The following is a description of a gene set: studied in species Mus musculus Mouse Gene Set: MIR_5619_5P Genes predicted to be targets of miRBase v22 microRNA mmu_miR_5619_5p in miRDB v6.0 with MirTarget v4 prediction scores > 80 (high confidence targets). from publication Chen Y, Wang X (PMID 31504780), and this is the list of marker genes: Wls, Hspa9, Psg16, Slc46a3, Zfta, Mindy2, Igf1, Cpped1, Herc4 (NCBI Gene Id 78516), Car2, Lalba, Slc16a4, Nfib, Ubr1, Pcmtd2, Oxct2b, Ggnbp2, Kat6b, Ikzf1, Pdzrn4, Krt27, Myh10, Ankib1, Sdcbp, Foxo4, Btg1, Ttr, Atad2, Vxn, Zfp366, Rassf3, Gpr82, Adra1b, Xpo7, Rab18, Ankrd44, Xpnpep3, Kat6a, Nus1, Emx1, Nsa2, Gucy1a2, Rnf128 (ring finger protein 128), Sele, Ankrd6, Ginm1, Syt11, Fgf1, Slc5a7, Map3k8, Zfp612, Prkar2b, Ube4b, Taf3, Kcna6, Ankrd63, Ttc3, Gabpb1, Gad2, Irak2, Ube2ql1